Given this list of marker genes Dmrt1, Mfn2, Nr5a1, Zfpm2 (NCBI Gene Id 320725), Dhx37, Cited2, Sema3a, Runx1, Sry, Wt1, Eif2s3y, Retn, Sox9, here is a description of the gene set: studied in species Mus musculus Mouse Gene Set: GOBP_POSITIVE_REGULATION_OF_GONAD_DEVELOPMENT Any process that activates or increases the frequency, rate or extent of gonad development.